Given this list of marker genes NTHL1, here is a description of the gene set: Several different mutations that result in truncation of NTHL1 protein have been described and associated with cancer. NTHL1 Q90TER (NTHL1 Gln90*) truncation mutant results from a nonsense mutation that replaces codon for glutamine 90 with a STOP codon. NTHL1 Q90TER has not been studied at the protein level, but is predicted to lack the DNA binding domain and the glycosylase domain, thus resulting in a complete loss of the base excision repair (BER) related DNA glycosylase function. Homozygous or compound heterozygous germline NTHL1 Q90TER mutation result in a cancer syndrome (NTHL1 associated tumor syndrome) that involves adenomatous polyposis, colorectal cancer breast cancer and multiple other types of cancer and benign tumors. Apart from NTHL1 Q90TER, at least seven other truncating variants have been identified in patients with NTHL1 associated tumor syndrome, such as NTHL1 A79fs (NTHL1 Ala79fs), NTHL1 Y130TER (NTHL1 Tyr130*), NTHL1 W182TER (NTHL1 Trp182*), NTHL1 c.709+1G>A, NTHL1 I245fs (NTHL1 Ile245fs), NTHL1 W269TER (NTHL1 Trp269*), NTHL1 Q287TER (NTHL1 Gln287*). species: Homo sapiens Reactome Pathway: Defective NTHL1 substrate binding part of: Defective Base Excision Repair Associated with NTHL1